Given this list of marker genes ALOX5, GGT3P, PAM, ELOVL6, HSD17B4, GCDH, ACSL4, ABCD1 (NCBI Gene Id 215), ACSL5, GGT1, GGTLC3, ABCD2, GGT5, ELOVL3, PPT1, ACSL1, HSD17B12, SLC27A5, EHHADH, ACACA, HMGCS2, ELOVL5 (ELOVL fatty acid elongase 5), ELOVL1, HACD1, AWAT2, SCP2, AWAT1, ELOVL7, ELOVL2, GGTLC2, ACOT8, GGTA1, HTD2, ACAT1, HACD2, ACOX1, ELOVL4, ALOX12, HMGCLL1, FASN, FAR1 (NCBI Gene Id 84188), ALOX15B, AACS, HMGCL, TECR, ALOX15, CBR4, SLC27A2, ACSBG2, ACSF3, ACSL3, TMEM135, FAR2, GGT2P, GGT7, ACSS3, FADS2, GGTLC1, GGT6, ACSBG1, ACSL6, PPT2, here is a description of the gene set: The chemical reactions and pathways resulting in the formation of fatty acid derivative. studied in species Homo sapiens Human Gene Set: GOBP_FATTY_ACID_DERIVATIVE_BIOSYNTHETIC_PROCESS